The following is a description of a gene set: Human Gene Set: HP_PES_CAVUS Pes cavus An increase in height of the medial longitudinal arch of the foot that does not flatten on weight bearing (i.e., a distinctly hollow form of the sole of the foot when it is bearing weight). species: Homo sapiens, and this is the list of marker genes: HSD17B4, IBA57, PEX5, SLC33A1, TRIM2, IDUA, TTN, DCC, SLC25A1, CBS, CHD7, GBA2, JAG1 (NCBI Gene Id 3715), HADHB, PODXL, NDNF (NCBI Gene Id 79625), PLIN4, FGF17, SLC5A7, CTCF, PDXK, MORC2, ITGA7, PNPLA6 (patatin like phospholipase domain containing 6), PI4K2A, SLC25A46, GJB1, MTTP, ANOS1, GRIN2A, BSCL2, VPS13A, KLC2, KARS1, COQ8A, INF2, WDR11, VWA1, ATG7, AARS1, SACS, COL13A1, CAPN1, LIPE, FBN1, ERLIN2, FLNA, NFIX, LAS1L (LAS1 like ribosome biogenesis factor), PLEKHG5, SPG11, NIPA1, HK1, LONP1, KIF5A, RAB11B, DCAF8, MTRFR, LBR, NEFL, HDAC8, TWNK, COL6A1, POLG, SPEG, COA7, COASY, PEX10 (NCBI Gene Id 5192), FGD4, SAMD9L, ATP6V1B2, IQSEC2, IMPDH2, HSPD1, PMP22, TTPA, RAB7A, NLRP3, AGRN, SUZ12, ERCC4, EMILIN1, WASHC5, ASCC3, POLR1A, MAP1B, PIK3CD, DHH, DYSF, USP9X, COQ7, IFIH1, REPS1, HSPB1, GJC2, PCNA, XRCC4, DDHD2, KCNN3, DNAJB2, GNS, B4GALNT1, GTF2E2, UBE2A, COL27A1, HACD1, FITM2, RYR1, CYP7B1, PMP2, SOX10, KLHL41, LMNA, DYNC1H1, CYP27A1, NDRG1, LRSAM1, ACTA1, COX6A1, SYNJ1, IL17RD, CPT1C, PIGN, PROKR2, ERCC5 (ERCC excision repair 5, endonuclease), FXN, HEXB, HINT1, PHYH, RTN2, MYPN, MYL2, NF1, SYT2, IFRD1, ABHD12, CNTNAP2, DHTKD1, MAP3K7 (NCBI Gene Id 6885), FBXO38 (F-box protein 38), GAN (NCBI Gene Id 8139), MECP2, LAMP2, KNSTRN, ATP1A3, AAAS, PMPCA, HADHA, DMXL2, APTX, SELENON, SETX, TPM2, SH3TC2, FGFR1, MRE11, CTDP1, SPG7, AHDC1, SETBP1, KY, ATP13A2, GMPPA, PQBP1, B3GLCT, GALC, MAD1L1, TPM3 (NCBI Gene Id 91191), NSUN2, ATP1A1, ATL1, MPZ, KIF1B, NEB, FLRT3, FGF8, GARS1, GJB2, HS6ST1, PEX2, NRCAM, WARS1, HARS1, FDX2, SCO2, L1CAM, SPART, MSTO1, PLAAT3, AIFM1, WDR73, MME, NEFH, TACR3, VRK1, REEP2, VPS41, FEZF1, BICD2, PRPS1, MED25, ALDH18A1, SPTLC1 (NCBI Gene Id 3302), SIGMAR1 (NCBI Gene Id 80768), LITAF, SPTAN1, PDK3, HESX1, WDR26, PRX, PI4KA, KCNH1, DNM2, FGF14, CAV3, CHAT (NCBI Gene Id 1103), HSPB8 (heat shock protein family B (small) member 8), SLC6A8, SEMA3A, DDHD1, RSPRY1, GLB1, ATP7A, PCGF2, MYMX, VCP, SPEN, GNB4, FHL1, DUSP6, UBAP1, SNAP25, PEX7, H3-3B, CUL4B, CARS1, ADPRS, ZBTB20, GCH1, SPAST, PYROXD1, GDAP1, PNKP, PLP1, SORD, PDHA1, MCM3AP, CHMP1A, SYNE1, TRPV4, ANO10, FLRT1, OPA1, GBA1, KANSL1, ZFYVE26, CHP1, MPV17, EZH2 (NCBI Gene Id 392834), SLC18A3, CCDC141, CHCHD10, MYH7, ADCY6, VPS13D, RET, SPRY4, KPNA3, IDS, BIN1, NSD1, ITPR3, TRAPPC11, GBF1, DNM1L, ALS2, EGR2 (early growth response 2), PROK2, VAMP1, TH, REEP1, UCHL1, TNNT1, MAFB, MFN2, BAG3, SBF2, DNAJC6, GOSR2, TSPOAP1, MAP3K20, XPA, FBLN5, C19orf12, MMP2, OPA3, MYO9A, TDP1, PNPT1, NR4A2, RUSC2, KBTBD13 (NCBI Gene Id 651356), NARS1, EIF2AK2